Given this list of marker genes AFP, PXYLP1, GPC1, CCNY, GPC6, APOBR, SLC35C2, ALDH1A1, DUSP4, here is a description of the gene set: Human Gene Set: GAUSSMANN_MLL_AF4_FUSION_TARGETS_D_DN The reciprocal chromosomal translocation t(4;11) is correlated with infant, childhood, adult and therapy-related high-risk acute leukemia. Here, we investigated the biological effects of MLL.AF4, AF4.MLL or the combination of both reciprocal fusion proteins in a conditional in vitro cell culture model system. Several parameters like cell growth, cell cycling capacity, apoptotic behavior and growth transformation were investigated under physiological and stress conditions. Co-transfected cells displayed the highest resistance against apoptotic triggers, cell cycling capacity and loss-of-contact inhibition. These analyses were complemented by gene expression profiling experiments and specific gene signatures were established for each of the three cell lines. Interestingly, co-transfected cells strongly upregulate the homeobox gene Nanog. In combination with Oct4, the Nanog homeoprotein is steering maintenance of pluripotency and self-renewal in embryonic stem cells. Transcription of Nanog and other stem cell factors, like Oct4 and Bmi1, was verified in biopsy material of t(4;11) patient cells which express both reciprocal t(4;11) fusion genes. In conclusion, the presence of both reciprocal MLL fusion proteins confers biological properties known from t(4;11) leukemia, suggesting that each of the two fusion proteins contribute specific properties and, in combination, also synergistic effects to the leukemic phenotype. species: Mus musculus from publication Gaussmann A, Wenger T, Eberle I, Bursen A, Bracharz S, Herr I, Dingermann T, Marschalek R (PMID 17130830) Down-regulated genes from the set D (Fig. 5a): specific signature shared by cells expressing MLL-AF4 alone and those expressing both MLL-AF4 and AF4-MLL fusion proteins.